Given this list of marker genes Frmd4a, Cycs, Oas3, Kpna3, Irf7, Psma7, Cox6b1, Rnf213, Tspo, Med30, Prdx1, Ifi44, Ifitm3, Usp18, H2-Q4, Snx2, Ifi35, Rsad2, Fen1, Pfn1, Fdps, Ifi207, Ifi47, Srsf7, Dhx58, Ptbp1, Ube2g1, Ppa1, Zbp1, Ms4a4c, Lgals9, Ifi205, Eloc, Arl8b, Snrpa, Txn1, Trim30a, Ppia (NCBI Gene Id 268373), Serpina3g, Socs1, Tk1, Stmn1, Ifi204, Irgm1, Dek, Xaf1, Map2k1, Itm2b, Isg20, Trim12a, Taldo1, Ly6a, Psme2, Mbd2, Slbp, Cxcl9, Stip1, Mx1 (MX dynamin-like GTPase 1), Sct, Herc6, Sp100, Acadl, Pnp, Ube2l6, Ly6e, Bst2, Csrp1, Phf11b (PHD finger protein 11B), Cd47, Ranbp1, Ldha, Pttg1, Ccdc86, Sumo1, Lgals3bp, Isg15, Myl12a, Cfl1, Oasl1, Tmsb10, Cuta, Akr1a1, Psmb9, Ifi211, Fdx1, Ifi27l2a, Nifk, Ass1, Psme1, Fmc1, Trim30d, Ostf1, Dnaja2, here is a description of the gene set: Cytokines mediate cell-cell communication in the immune system and represent important therapeutic targets. A myriad of studies have highlighted their central role in immune function, yet we lack a global view of the cellular responses of each immune cell type to each cytokine. To address this gap, the authors created the Immune Dictionary, a compendium of single-cell transcriptomic profiles of more than 17 immune cell types in response to each of 86 cytokines (>1,400 cytokine-cell type combinations) in mouse lymph nodes in vivo. A cytokine-centric view of the dictionary revealed that most cytokines induce highly cell-type-specific responses. For example, the inflammatory cytokine interleukin-1β induces distinct gene programmes in almost every cell type. A cell-type-centric view of the dictionary identified more than 66 cytokine-driven cellular polarization states across immune cell types, including previously uncharacterized states such as an interleukin-18-induced polyfunctional natural killer cell state. Mouse Gene Set: CUI_CDC1_IFNL2_RESPONSE_UP species: Mus musculus Genes positively differentially expressed in cell type: cDC1 (conventional dendritic cell type 1) upon treatment with cytokine: IFN-λ2 in mouse lymph nodes in vivo. from publication Cui A, Huang T, Li S, Ma A, Pérez JL, Sander C, Keskin DB, Wu CJ, Fraenkel E, Hacohen N (PMID 38057668)